Given this list of marker genes CTBP1, STAG2, TRRAP, DIS3L2, MEGF8, PIGG, MYRF, BRD4, ADGRG6, MID1, MAMLD1, HES7, RLIM, RPS28, COX7B, MYCN, MCTP2, WNT7B, RAD21, SF3B4, ARID1B, PORCN, KIAA0586, LRP2, HDAC4, NELFA, RARB, TRIP4, SH2B1, MESP2, HOXD13, KDM6A, CD96, MAP3K7, FBLN5, MYT1L, IGHMBP2, KDM3B, RPS26, RSPO2, ZNF699, NIPBL, MN1, KMT2D, RIPPLY2, PBX1, HDAC8, ALG9, HCCS, TRAIP, PCNA, SMC3, PPM1D, SEC31A, PIGN, MTHFR, PLOD3, LETM1, ACTA1, KLHL40, NEB, DHCR7, GATA6, GDAP1, EFEMP1, POLR1A, REEP1, FLNA, SLC2A10, NDUFB11, EFEMP2, ALDH1A2, NUAK2, GPC3, STRA6, LMOD3, NSD2, CHUK, MEGF10, KLHL41, GATA4, ANAPC7, CPLX1, NDUFAF5, ERF, GPC4, POGZ, MAFB, SMARCB1, NR2F2, SIN3A, WT1, AR, DACT1, DNAJC19, ABL1, KCNA1, HYLS1, SMC1A, LFNG, DLL3, ASNS, ADAT3, CDC42BPB, SMAD2, LONP1, ARID2, TAF6, LTBP4, WLS, GLI3, CHST3, VANGL2, B3GAT3, ZFPM2, WNT3, GNE, KIF7, MYOD1, MAF, GNB2, MTM1, EFNB1, WNT4, PLS3, CHRNG, here is a description of the gene set: Abnormality of the diaphragm species: Homo sapiens Human Gene Set: HP_ABNORMALITY_OF_THE_DIAPHRAGM Any abnormality of the diaphragm, the sheet of skeletal muscle that separates the thoracic cavity from the abdominal cavity.